The following is a description of a gene set: A number of IFN-induced proteins are believed to be responsible for the antiviral state induced by IFNs. Our microarray analysis of IFN-regulated genes in MEFs from wild-type mice identified 124 probe sets that were differentially regulated upon IFN treatment. This group consisted of many known ISGs such as Ifit1, Gbp2, mx1, Isg15, Stat1, nmi, mx2, If204, Adar, Irf1, and protein kinase R. from publication Pfeffer LM, Kim JG, Pfeffer SR, Carrigan DJ, Baker DP, Wei L, Homayouni R (PMID 15131130) Genes up-regulated in mouse embryonic fibroblasts (MEF): untreated versus interferon beta. studied in species Homo sapiens Human Gene Set: GSE3400_UNTREATED_VS_IFNB_TREATED_MEF_UP, and this is the list of marker genes: MMP7, NDUFV2, CHST7, OLR1, MFAP3, ATP13A3, PAXBP1, DOCK10, BNIP3L, CDKN2AIP, KRAS, TMEM14C, HMGB2 (NCBI Gene Id 3148), JTB, PTGER2, ATP2C1, SLC9A6, MSH2, ZNF559, TPST1, SERINC5, LPCAT1, NUP155, CUTC, DPY19L1, FBXL5, ZCCHC9, LINC02877, LRPAP1, ZNF407-AS1, ADAM9, KMO, GALNT1, ZNF45, METTL14, TRAIP, GAPT, FGF14-IT1, ZBTB44, ALAD, LYPLAL1, SLTM, HECA, GNAS, RNASEL, ARHGAP35, ADAP2, TMEM170B, SIMC1, ITGB1, ZMYND11, HEATR6, ETFB, IPO9 (importin 9), TMEM245, ANKS1B, ZNF780A, TBC1D9B, HTR7P1, HMGN1, NDRG4, GOLM2, GABARAPL2, AMMECR1, PIP4P2, FBXW2, GALNT7, NCOA1, PDPN, CNEP1R1, SIRPB2, DNAJC19, PMS2P2, SPG21, ACOX1, DHX29, FBXO9, MIR4453HG, CDC23, AKR1B1, LINC00921, MTMR6, MAEA, TUBGCP3, MARCHF6, RALGAPA2, SDCCAG8, FAM168B, BRD7, RTN1, NTSR1, TNKS, PBX3 (NCBI Gene Id 5090), UBE2E3, CD81, TRAPPC11 (trafficking protein particle complex subunit 11), ANKRA2, C1orf122, ZNF23, BRI3, CENPC, GLIS3, ETFRF1, TULP4, KYNU, PIGC, CCSAP, HMGB1, CD302, WDSUB1, MILR1, C10orf55, RDH11, DOCK5, IDH2, CDC40, ZDHHC6 (zinc finger DHHC-type palmitoyltransferase 6), GGH, MAPK1, CERT1, ATG2B, MTIF3, TUG1, CETN3, RPP14, PJA1, AGO2, GMCL1, SERINC3, TSG101, COA5, TMEM39B, RNF44, GPR160, TESMIN (NCBI Gene Id 9633), TMCO3, NUDT14, DDX17, PHF21A, FH, SLC6A6, NRP1, ZZEF1, PROS1, CUX1, SHPRH, SH3BGRL, RGP1, PINK1, SPOPL, DCAF12, PCGF6, DENND11, ZNF304, LEPROT, GAS2L3, PHF10, CITED2, KLHL9, RNF130, LYSET, TAF8 (NCBI Gene Id 135763), ARMCX3, LYL1, CPQ, PAIP2, PELI2, RACGAP1, NBR1, RPGR, GZF1, MMUT, ATOSA, PRDM10, SPEN, WDR37, RAP1A, SMC1B, TBRG1, RAB4A (NCBI Gene Id 5867), HIPK2, TASOR, PPWD1, IRS2, DCAF11, ZBED5 (NCBI Gene Id 58486), PLEKHM3, CSGALNACT2, MAPK9, MPHOSPH6, DHRS7, DENND4C, DMXL1, GSK3B